Given this list of marker genes Cipc, Cry2, Drd2, Ptger3, Ghrl, Lepr, Sin3a, Per2, Ada, Drd1, Piwil2, Pasd1, Cry1, Adora1, Sfpq, here is a description of the gene set: Mouse Gene Set: GOBP_NEGATIVE_REGULATION_OF_CIRCADIAN_RHYTHM Any process that stops, prevents, or reduces the frequency, rate or extent of a circadian rhythm behavior. studied in species Mus musculus